The following is a description of a gene set: species: Homo sapiens Human Gene Set: GOBP_GRANULOCYTE_COLONY_STIMULATING_FACTOR_SIGNALING_PATHWAY The series of molecular signals initiated by the binding of the cytokine granulocyte colony-stimulating factor (G-CSF) to its receptor on the surface of a target cell, and ending with the regulation of a downstream cellular process, e.g. transcription. G-CSF binds to the receptor (CSF3R)., and this is the list of marker genes: HAX1, CEACAM1, CSF3, JAGN1, HCLS1